Given this list of marker genes VPS4B, CCDC15, PPP1R35, POC1B, CEP295, CENPJ, CEP120, here is a description of the gene set: species: Homo sapiens Any process that activates or increases the frequency, rate or extent of centriole elongation. Human Gene Set: GOBP_POSITIVE_REGULATION_OF_CENTRIOLE_ELONGATION